Given this list of marker genes PGLS, RPEL1, ALDOB, RPE, MTOR, TKT, TIGAR, RPTOR, PRPS2, H6PD (hexose-6-phosphate dehydrogenase/glucose 1-dehydrogenase), TALDO1, TP53, SHPK, MLST8, G6PD, ACACB, RPIA, PGD, RBKS, DERA, here is a description of the gene set: The metabolic process in which glucose-6-phosphate is oxidized to form carbon dioxide (CO2) and ribulose 5-phosphate, coupled to reduction of NADP+ to NADPH; ribulose 5-P then enters a series of reactions that can yield biosynthetic precursors (ribose-5-phosphate and erythrose-4-phosphate) and glycolytic intermediates (fructose-6-phosphate and glyceraldehyde-3-phosphate). studied in species Homo sapiens Human Gene Set: GOBP_PENTOSE_PHOSPHATE_SHUNT